The following is a description of a gene set: Binding to a protein involved in the process of removing sections of the primary RNA transcript to form the mature form of the RNA. Human Gene Set: GOMF_SPLICING_FACTOR_BINDING species: Homo sapiens, and this is the list of marker genes: SF3B5, DYRK1A, RBM14, SF3B1, SF3B4, RBM20